The following is a description of a gene set: Any process that activates or increases the frequency, rate or extent of behavior, the internally coordinated responses (actions or inactions) of whole living organisms (individuals or groups) to internal or external stimuli. Mouse Gene Set: GOBP_POSITIVE_REGULATION_OF_BEHAVIOR species: Mus musculus, and this is the list of marker genes: Agrp, Cckbr, Vps35, Sgip1, Gria1, Mtnr1b, Uts2, Crh, Npas2, Nps, Gja1, Mef2c, Uts2r, Casp1, Nr2c2, Pmch, Ghrl, Ucn, Ptger4, Nr4a3, Oprk1, Penk, Grpr, Drd1, Ghrhr, Ghsr, Mtor, Alb, Cfap20, Cck, Insl5, Adora2a (adenosine A2a receptor), Ptger3, Npy2r, Rxfp4, Grp, Ghrh, Npy, Hdac4, Mc1r, Hdac2 (histone deacetylase 2), Stra6, Nlgn1